The following is a description of a gene set: Genes down-regulated in DU-145 cells (prostate cancer) in the absence but not in the presence of a dominant negative form of AKT1 upon exposure to HGF for 48 h. Human Gene Set: XU_HGF_TARGETS_INDUCED_BY_AKT1_48HR_DN from publication Xu J, Gao M, Fan S, Meng Q, Goldberg ID, Abounader R, Ressom H, Laterra JJ, Rosen EM (PMID 17099727) The cytokine scatter factor (SF) (hepatocyte growth factor) transduces various biologic actions, including cell motility, invasion, angiogenesis and apoptosis inhibition. The latter is relevant to understanding the role of SF in promoting tumor cell survival in different contexts, for example, detachment from basement membrane, growth in metastatic sites and responses to chemo- and radiotherapy. Previously, we showed that SF protects cells against apoptosis owing to DNA damage, by a mechanism involving phosphoinositol-3-kinase/c-Akt signaling. Here, we used DNA microarray assays to identify c-Akt-regulated genes that might contribute to cell protection. DU-145 human prostate cancer cells were transfected+/-a dominant-negative mutant Akt, treated+/-SF and analysed for gene expression using Affymetrix arrays. These studies identified SF-regulated genes for which induction was c-Akt-dependent vs -independent. Selected microarray findings were confirmed by semiquantitative and quantitative reverse transcription-polymerase chain reaction. We tested the contribution of four SF-inducible/c-Akt-dependent genes (AMPD3, EPHB2, MX1 and WNT4) to protection against adriamycin (a DNA topoisomerase IIalpha inhibitor) using RNA interference. Knockdown of each gene except EPHB2 caused a small but significant reduction in the SF cell protection. The lack of effect of EPHB2 knockdown may be due to the fact that DU-145 cells contain a single-mutant EPHB2 allele. A combination of three small interfering RNAs blocked most of the protection by SF in both DU-145 and T47D cells. These findings identify novel c-Akt-regulated genes, some of which contribute to SF-mediated cytoprotection. species: Homo sapiens, and this is the list of marker genes: TXN, KIF23, SUGP2, NFYB, KIF14 (NCBI Gene Id 9928), CENPA, GSX1, CARMIL1, ZNF268, FTH1P5, PRP4K, MCOLN3, SPC25, GOLGA8A, CCNL1, SNCA, SMC4, HMMR, CXCL12, CDCA3, F7, KIAA0586, RSRP1